Given this list of marker genes TSHZ2, PCCA, SHOC2, FOXC1, KIAA0825, DAB2, COA7, PPFIA2, RIC1, PRXL2C, SRGAP2C, CEP57, HNRNPC, OSGEPL1, MBNL1, NLN, AHR, UTP25, TMEM65, PM20D1, HSF5, KLHL14, ADGRE3, AMER2, P4HA1, KLHL5, FOXP2, TGFA, COL8A1, GTF2A1, WDR89, BRINP3, NADSYN1, HAUS6 (NCBI Gene Id 54801), CRLF3, LAPTM5, DCLK1, ZNF875, DTNA, SLC25A5, A4GNT, DCUN1D3, THBS2, CLK4, NR3C1, SHE, GKAP1, LRP2BP, CLDND1, SERP1, CD83, ENDOD1, MAPK10, SAMD12, RNF138, C2CD4A, XPNPEP3, PTGDR, BMP3, SAYSD1, FUT9, TENT2, ICOS, IFT43, BASP1 (brain abundant membrane attached signal protein 1), COL17A1, THSD7A, PGM2L1, CIAO2A, ZSCAN1, RPS6KL1, RFXAP, HYCC2, GAN, ABI1, UBE2J1, CCAR1, here is a description of the gene set: Human Gene Set: MIR3136_5P Genes predicted to be targets of miRBase v22 microRNA hsa-miR-3136-5p in miRDB v6.0 with MirTarget v4 prediction scores > 80 (high confidence targets). from publication Chen Y, Wang X (PMID 31504780) species: Homo sapiens